The following is a description of a gene set: part of: Hedgehog 'off' state This event has been computationally inferred from an event that has been demonstrated in another species.<p>The inference is based on the homology mapping from PANTHER. Briefly, reactions for which all involved PhysicalEntities (in input, output and catalyst) have a mapped orthologue/paralogue (for complexes at least 75% of components must have a mapping) are inferred to the other species. Reactome Pathway: GLI3 is processed to GLI3R by the proteasome electronically inferred by orthology from the curated human pathway species: Mus musculus, and this is the list of marker genes: Psmd6, Ubb, Rps27a, Cul1, Psma7, Psma3, Psmb4, Psmd13, Psmb6, Psmd7, Psmc5, Psma5, Psmb5, Psmc6, Psmb7, Psma6, Prkaca, Gli3, Prkacb, Psma2, Psmd1, Psma4, Psmc1, Psmc4, Psmc3, Psmc2, Psma1, Csnk1a1, Psmd12